Given this list of marker genes Pop4, Gm4884, Rbm34, Ccar1, Exoc4, Ptprr (protein tyrosine phosphatase receptor type R), Slc5a6, Npas3, Suv39h2, Rptn, Khnyn, Slco6d1, Arf4 (NCBI Gene Id 30916), Slc38a4, Ipo9, Dram1, Fzd1, Syt5, Vps50, Nudt3, Atp5mk, Ark2n, Akap17b (NCBI Gene Id 338351), Tle1, Cpeb3, Tmem200a, Glrp1, 2210408I21Rik, Actl11, Cdx4, Cntd1, Zmym4, Gpr180, Med7, Paxbp1, Tspoap1, Tmcc1, Ranbp9, Cnp, Sephs1, Zfp397, Ccnt2, Ankrd55, Mbnl1, Wdr43, Scn3a, Steep1, Mark1, Nabp1, Scyl3, P4ha1, Susd6, Klhl15, Cdk5r2, Atg10, Mgat2, Lair1, Ptbp3, Ppp6c (NCBI Gene Id 67857), Vwce, Vps33b, Rer1, Ids, Cyp26b1, Fgr, Ankrd12, Atad1, Khdc1a, Elmod2, Cgas, Cpox, here is a description of the gene set: Mouse Gene Set: MIR_496A_3P from publication Chen Y, Wang X (PMID 31504780) species: Mus musculus Genes predicted to be targets of miRBase v22 microRNA mmu_miR_496a_3p in miRDB v6.0 with MirTarget v4 prediction scores > 80 (high confidence targets).